Given this list of marker genes Ip6k1, Pld4, Calm3, Impa1, Ppip5k2, Itpkc, Plcb4, Itpk1, Inpp5b, Plcz1, Isyna1, Plcd3, Inpp1, Plcd1, Plcb1, Plch1, Inpp5d, Plcg2, Ip6k2, Itpka, Inpp4a, Minpp1, Calm2, Itpkb, Ocrl, Plcb3, Inpp5j, Inpp5a, Miox, Inpp4b, Ipmk, Plch2, Ip6k3, Inppl1, Pten, Nudt11, Nudt4, Nudt10, Plcd4, Plcg1, Impa2, Calm1, Synj1, Ppip5k1, Nudt3, Plcb2, Plce1, Ippk, here is a description of the gene set: Inositol phosphate metabolism studied in species Mus musculus Mouse Gene Set: REACTOME_INOSITOL_PHOSPHATE_METABOLISM